The following is a description of a gene set: from publication Gavish A, Tyler M, Greenwald AC, Hoefflin R, Simkin D, Tschernichovsky R, Galili Darnell N, Somech E, Barbolin C, Antman T, Kovarsky D, Barrett T, Gonzalez Castro LN, Halder D, Chanoch-Myers R, Laffy J, Mints M, Wider A, Tal R, Spitzer A, Hara T, Raitses-Gurevich M, Stossel C, Golan T, Tirosh A, Suvà ML, Puram SV, Tirosh I (PMID 37258682) Human Gene Set: GAVISH_3CA_MALIGNANT_METAPROGRAM_35_HEMATO_RELATED_1 studied in species Homo sapiens Genes upregulated in subsets of cells of a given type within various tumors In this study, an extensive analysis was conducted to define meta-programs (MPs) capturing intra-tumor heterogeneity across a spectrum of tumor types. The approach utilized non-negative matrix factorization (NMF) to analyze each cell type separately within individual tumor samples. This involved the analysis of malignant cells, macrophages, fibroblasts, endothelial cells, epithelial cells, T-cells, and B-cells. NMF was executed with varying parameter values (K=4, 5, 6, 7, 8, 9), thereby generating 39 programs for each cell type per sample. Each NMF program was summarized by the top genes based on NMF coefficients.\nRobust MPs were then delineated for each cell type using a set of stringent criteria, including recurrence within the same tumor, similarity to programs in other tumors, and non-redundancy within a tumor. Subsequently, these robust NMF programs were clustered (per cell type) based on Jaccard similarity, leading to the identification of MPs associated with each cell type.\nTo enhance the quality of the MPs, a refinement steps were undertaken, involving the removal of MPs suspected of reflecting low-quality data (with an overrepresentation of ribosomal proteins or mitochondrial-encoded genes), single-study inclusion, or similarity to miss-annotated cell types., and this is the list of marker genes: CSF3R, IGLL1, SMIM24, HLA-DQB1, MGST1, PRTN3, PTPRCAP, ITM2C, CD74, KLF6, BAALC, ZFP36L2 (ZFP36 ring finger protein like 2), CRHBP, CD52, CD44, CLEC11A, CTSG, PLAC8, MBOAT7, SELL, RAB32, LYZ, ANKRD28 (ankyrin repeat domain 28), FAM30A, CPA3, ICAM3, SPINK2, VAMP5, AVP, C1QTNF4 (C1q and TNF related 4), TNFSF13B, RNASE2, TSC22D3, CD34 (NCBI Gene Id 947), MPO, MS4A3, ELANE, SRGN, PRSS57, ARMH1, BST2, NPDC1 (neural proliferation, differentiation and control 1), MDK, SERPINB1, FOS, GLIPR1, AZU1, CFD, CST7, HOPX